Given this list of marker genes DHRS3, RDH8, AKR1B15, DHRS4, RDH14, RDH10, AKR1C3, DHRS7, RDH11, RDH12, AKR1B1, RDH13, AKR1B10, here is a description of the gene set: Catalysis of the reaction: all-trans-retinol + NADP+ = all-trans-retinal + NADPH + H+. Human Gene Set: GOMF_ALL_TRANS_RETINOL_DEHYDROGENASE_NADPPLUS_ACTIVITY species: Homo sapiens